The following is a description of a gene set: Any deviation from the normal direction of the ventricular axis. The left ventricle makes up most of the heart muscle under normal circumstances and therefore generates the most electrical force visible on the EKG. The normal ventricular axis is directed downward and slightly towards the left. The ventricular axis can be determined by analyzing the QRS complex, which represents ventricular depolarization. studied in species Homo sapiens Human Gene Set: HP_ABNORMAL_VENTRICULAR_AXIS Abnormal ventricular axis, and this is the list of marker genes: MYH7, PLXND1, GAA, TNNT2, PRKAG2